The following is a description of a gene set: Neighborhood of CASP8 caspase 8, apoptosis-related cysteine peptidase in the GNF2 expression compendium studied in species Homo sapiens Human Gene Set: GNF2_CASP8 Neighborhood of CASP8, and this is the list of marker genes: PTPRC, BTN3A3, C11orf21, LCP2, ITGAL, STK38, MBNL1, RIGI, TRAF3IP3, ATM, CYTH1, SNRK, BIN2, FYB1, GIMAP6, CASP8, HECA, CYTIP, ARHGAP45, STK10, BTN3A1, GIMAP4, BTN3A2, PARP8 (NCBI Gene Id 79668), RNF44 (NCBI Gene Id 260352), TMC6, SEMA4D